Given this list of marker genes Bcl7a, Neto1, Bin1, Atg14, Cd151, Sgsm2, Kcnc2, Krtap17-1, Cc2d1b, B3gnt6, Jcad, Smim10l1, Pard3, Zswim5 (zinc finger SWIM-type containing 5), Mlxipl, Map3k7, Zc3h12c, Actr2, Rnf20, Hnrnpm, Pip4p2, B3galt5, Gprasp1, Capza2, Ostm1, Tspan13 (tetraspanin 13), Trappc14, Ankrd27, Strbp (spermatid perinuclear RNA binding protein), Arid1a, Sult2a4 (sulfotransferase family 2A, dehydroepiandrosterone (DHEA)-preferring, member 4), Thumpd1, Aqp4, Scd1, Tnrc6b, Slc25a3, Cyld, Sult2a1, Cd34, Hpse2, Adamts15, Hnrnpd, Pcsk5, Sycp3, Kpna1, Hnrnpk, Sult2a2, Pfkfb2, Abca1, Timm22, Wdr6, Tnik, Azi2, Phf6, Sertad4, Nptn, Krtap10-31, Pramel12, Padi2, Hdgfl3, Nt5c3, Srrm2, Celf2, Rnf152, Slc25a14, Gm5878, Swt1, Zbtb7c, Map4k3, Gpatch2l, Zeb1 (zinc finger E-box binding homeobox 1), Epc1, Gja8 (gap junction protein, alpha 8), Ch25h (NCBI Gene Id 12642), Flot1, Tmem87a, Zfp609, Lrit2, Hecw2, Fhip1a, Dapk2, B230219D22Rik, Tet2, Foxa1, Ctbs, Kctd8, Atp8b2, Crxos, Cdh1, Tnfrsf10b, Foxk2, Ssbp2, Agpat5, Pou3f2, Yipf4, Ccin, Tnp2, Tmem266, Serpina3f, Adcy3, Acnat1, Prr16, Rora, Nr1d2, Katnb1, Prkaa1, Pgk1, Erlin2, Zc4h2, Upf3b, Ide, Abcc5 (NCBI Gene Id 78340), Hars2 (histidyl-tRNA synthetase 2), Rgs17 (regulator of G-protein signaling 17), Map3k12, Sult2a5, Cacnb4, Pramel16, here is a description of the gene set: Mouse Gene Set: MIR_7220_3P Genes predicted to be targets of miRBase v22 microRNA mmu_miR_7220_3p in miRDB v6.0 with MirTarget v4 prediction scores > 80 (high confidence targets). species: Mus musculus from publication Chen Y, Wang X (PMID 31504780)